The following is a description of a gene set: Human Gene Set: GSE20715_WT_VS_TLR4_KO_48H_OZONE_LUNG_DN from publication Bauer AK, Rondini EA, Hummel KA, Degraff LM, Walker C, Jedlicka AE, Kleeberger SR (PMID 21543283) We previously identified toll-like receptor 4 (Tlr4) as a candidate gene responsible for ozone (O3)-induced pulmonary hyperpermeability and inflammation. The objective of this study was to determine the mechanism through which TLR4 modulates O3-induced pulmonary responses and to utilize transcriptomics to determine TLR4 effector molecules. C3H/HeJ (HeJ; Tlr4 mutant) and C3H/HeOuJ (OuJ; Tlr4 normal), mice were exposed continuously to 0.3 ppm O3 or filtered air for 6, 24, 48 or 72 hr. Affymetrix Mouse430A_MOE gene arrays were used to analyze lung homogenates from HeJ and OuJ mice followed using a bioinformatic analysis. Inflammation was assessed by bronchoalveolar lavage and molecular analysis by ELISA, immunoblotting, and transcription factor activity. TLR4 signals through both the MYD88-dependent and independent pathways in OuJ mice, which involves MAP kinase activation, NF-kappaB, AP-1, and KC. Microarray analyses identifiedTLR4 responsive genes for strain and time in OuJ versus HeJ mice (p<0.05). One significantly upregulated cluster of genes in OuJ were the heat shock proteins (Hspa1b; Hsp70), Hsp90ab1). Furthermore, O3-induced expression of HSP70 protein was increased in OuJ compared to HeJ mice following 24-48 h O3. Moreover, BAL polymorphonuclear leukocytes (PMN) and total protein were significantly reduced in response to O3 in Hspa1a/Hspa1btm1Dix (Hsp70-/-) compared to Hsp70+/+ mice (p<0.05). TLR4 signaling (MYD88-dependent), ERK1/2, AP-1 activity, and KC protein content were also significantly reduced after O3 exposure in Hsp70-/- compared to Hsp70+/+ mice (p<0.05). These studies suggest that HSP70 is involved in the regulation of O3-induced lung inflammation through the TLR4 pathway and provide evidence that HSP70 is an endogenous in vivo TLR4 ligand. studied in species Homo sapiens Genes down-regulated in comparison of lung tissue from wild type mice subjected to ozone for 48 h versus that from TLR4 deficient mice subjected to ozone for 48 h., and this is the list of marker genes: SEC61B, ACOT7, UBQLN4, HMGCS1, ACOT2, TRIM6, NDUFA4, DUSP12, WWP2, FDFT1, BIN3, KCTD2, TOM1, ITGA9, TUBA1A, LRPPRC, ATF1, GAL3ST1, SHFL, PRRC2A, ADAM17, NSMCE3, NIBAN2, TRIM13, SCNN1B, MSTO1, SLC26A4, NOXO1, EMC7, HNRNPD, HK1, ABCA7, DMKN, TMBIM1, NMT1, VWF, TADA1, EIF4G1, LRRC49, H1-0, NAGLU, GDA (guanine deaminase), EIF1AX, MLLT10, ELF5, MRPL12, MYG1, WSB2, GAA, PIH1D1, TGFB3, BLCAP, ELP1, IL18R1, POF1B, MRPL52, TTYH2, PARP9, MRPS2, SEPTIN11, NDUFV2, RBM43, CKAP4, WNK4, CKB, PEX7, EYA2, GPX2, AP1M2, HDHD3, PRR13, NAF1, FADD, JMJD1C, SSRP1, ODC1, PHLDA3 (pleckstrin homology like domain family A member 3), ADSS1, NUDT6, GALC (galactosylceramidase), CYSTM1, PABIR1, ARPC1B, RENBP, CENPV, EXOSC4, FAM13B, HP, SMU1, GADD45G, SUMO3, ELP2, PLSCR3, DRAM1, DBI, TRMT5, ACOX2, CHUK, ARCN1, ING2, SOX2, TADA2A, PIK3C2A, PPCS, RAP2B, HINT2, EPCAM, DYNLT1 (dynein light chain Tctex-type 1), PCCA, TMEM243, PPP1R21, SQOR, XPR1, LASP1, SELENOM, RTL6, ATP7A, DCTN4, DLST, REX1BD, CASP3, C4orf19, LDLR, ALG2, ARFGAP1, SCRIB, APPL2, RSPH9 (NCBI Gene Id 221421), TACSTD2, PLEKHB1, TEN1, WDR75, TMED2, NPEPL1, EXOSC7, MRPL2, KPNA1, NUDT1, MFAP3, HEATR1 (HEAT repeat containing 1), COX5A, PSMD2, SUSD6, TIMM10B, ALDH3A1, TRIM3, SMIM11, TOMM70, AP3M1, MTFR1L, ALG3, CXCL6, FSTL1, ALDOA, TMEM160, TUFT1, SLC39A7, NUPR1, S100A16, RSL24D1, ANKRD54, CALHM5, PAFAH2, SFMBT2, SH3BP5, SRSF9, PLEKHA1, DDX3Y, PGD, CMPK1, LPCAT3, NPC2, MRPS28, LRRC14, CREB3L1, PTPRE, PTGS1, RECQL5, CYP1B1, SLC25A35, MYO9B, HINT1, PRPF31, ZBTB18, NEPRO, HPN, AGR3, STRN4, SPON2, ATP6V1H, CC2D1A, RANBP3, ITGA7, IL1R1, IDI1, ATP6V0A1, GTF2F1, RBM17, SQLE, MRPL58